Given this list of marker genes SLAMF8, IGHA2, RPS19, DUSP10, NOXO1, BCR, JCHAIN (joining chain of multimeric IgA and IgM), GRN, CAMK1D, RAC1, NCF1, RAC2, INS (insulin), IGHA1, NOXA1, LBP, INSR, S100A9, CLEC7A, here is a description of the gene set: species: Homo sapiens Human Gene Set: GOBP_REGULATION_OF_RESPIRATORY_BURST Any process that modulates the rate frequency or extent of a phase of elevated metabolic activity, during which oxygen consumption increases; this leads to the production, by an NADH dependent system, of hydrogen peroxide (H2O2), superoxide anions and hydroxyl radicals.